The following is a description of a gene set: Genes having at least one occurence of the motif TCTGGAC in their 3' untranslated region. The motif represents putative target (that is, seed match) of human mature miRNA hsa-miR-198 (v7.1 miRBase). species: Homo sapiens Human Gene Set: TCTGGAC_MIR198, and this is the list of marker genes: HMGA1, NRIP1, STAT6, BCL7A, MET, PDCD1LG2, CPNE8, H3-3A, NRXN1, STOML1, CRYBG2, TOX2, QKI, RAD54B, ADNP, KDM2B, APH1A, PTEN, JPH4, FUT8, PUM2, PHF6, TCEA1, SMOC1, CNR1, BSN, PIAS4, LSM12 (NCBI Gene Id 124801), RPUSD3, SCAF1, NCOR2, FAAH, HNRNPU, UNG, HERC4, KCND1, MSR1, GLYR1, ARID1A, PBX1, TCF7L1, PCDH19, AP3B1, SAR1A, POGZ, TGOLN2, TNRC6B (trinucleotide repeat containing adaptor 6B), CDCP1, FIGN (NCBI Gene Id 80249), SLC25A27, PPP1R9B, NNAT, KCNH4, AKAP1, BTN2A1, PLXDC2, TRNP1, ATG16L1, SLC2A1, ZNF821, CREB5, TSHZ1, KLHDC10 (kelch domain containing 10), VCP, OTX1 (orthodenticle homeobox 1), AMMECR1L, SHISA5, PHF12, SUMO1, DAZAP1, OTX2, LHX4, TOPORS, DUSP13B, ABCF2, ZNF362, LETMD1, RIMKLA (NCBI Gene Id 284716), CAPN3, SLITRK5, PURA, NR2C2, ERC2, MED13L